Given this list of marker genes Aldob, Aldh1a1, Glyctk, Khk, Tkfc, here is a description of the gene set: Fructose catabolism species: Mus musculus Mouse Gene Set: REACTOME_FRUCTOSE_CATABOLISM